The following is a description of a gene set: from publication Chen Y, Wang X (PMID 31504780) Human Gene Set: MIR802 studied in species Homo sapiens Genes predicted to be targets of miRBase v22 microRNA hsa-miR-802 in miRDB v6.0 with MirTarget v4 prediction scores > 80 (high confidence targets)., and this is the list of marker genes: PSMD2, FBXO22, FIGN, AGRN (agrin), ZBTB41, FAM171B, CDK6, ARPP19, SLC14A1, PRKAA1, RRAS2, LEPROT, SOD2, SV2C, POLR3A, UTP15, SLC10A7, LINGO2, EPM2AIP1, ADAMTS1, AGTR1, PIP5K1A, CPSF6, TLL1, REDIC1, UTS2B, AUTS2, RCOR1, TSHR, PCDH19, ADGRL3, ITM2B, PTCH1 (patched 1), ANKRD40 (NCBI Gene Id 91369), HIPK3, TUBE1, CFLAR, CREB1 (cAMP responsive element binding protein 1), MAMDC2, EPC1, EIF4E, SCARF1, PBK, ALG8, TCF7L2, TMEM123, ARL6IP6, HS6ST3, QSER1, ARMC8, SNX10, TMTC1, RP2, TP53INP1, BTG2, RICTOR, ZFHX3, CDC23, SECISBP2L, TASOR, ZNF10, CPEB3, ANXA5, PSMD5, FAT4, RBM6, SSR1, CCNY, CSE1L, CHN1, TRIM71, PAIP1, RTN1, ZNF250, XPNPEP3 (NCBI Gene Id 63929), SEC62, ZBTB6, STEAP2, NIPBL, ADAMTS9 (NCBI Gene Id 56999), DCAF13, LPAR4, LNX2, UCKL1, TAF4B, CD274 (NCBI Gene Id 29126), ACYP2, C16orf87, ZFPM2, CAMTA1, ACBD3, SRGN, ERICH2, PHF8, OMA1, CDK1, SIX1 (SIX homeobox 1), RRAGA, EPHA7, KITLG, MINDY2, MYO10, CBFB, EHF (NCBI Gene Id 26298), MRPS27, SLC9B1 (NCBI Gene Id 150159), CEP97, LGR5, MTMR1, G2E3, SLC6A15, CIT, SCAMP1, TRIB2, MCIDAS, CACNA2D1, SAMD8, MICU3, ZCCHC9, RASGEF1B, C4orf3, BTF3L4, NEXMIF, LAGE3, DIS3, SOCS2, BEND4, MAP6D1 (MAP6 domain containing 1), IVL, OTULINL, KLLN, PHTF2, CALM2